Given this list of marker genes Gja5, F2r, Ptpro, Uts2, Uts2r, Cyba, Ttr, here is a description of the gene set: studied in species Mus musculus Mouse Gene Set: GOBP_NEGATIVE_REGULATION_OF_GLOMERULAR_FILTRATION Any process that stops, prevents, or reduces the frequency, rate or extent of glomerular filtration. Glomerular filtration is the process whereby blood is filtered by the glomerulus into the renal tubule.